Given this list of marker genes AGO3, CDH1, MYCN, MOV10, AGO2, MIR10B, MIR9-3, TNRC6C, AGO1 (NCBI Gene Id 26523), MIR9-2, MIR9-1, TNRC6B, AGO4, MYC, TNRC6A, here is a description of the gene set: Reactome Pathway: Regulation of CDH1 mRNA translation by microRNAs part of: Regulation of CDH1 Expression and Function <p>Regulation of CDH1 mRNA translation by microRNAs has not been extensively characterized. So far, miR-9 (miR-9-1, miR-9-2, and miR-9-3) microRNAs, whose expression is regulated by MYC/MYCN, and miR-10b were reported to directly regulate CDH1 mRNA translation by more than one study.</p><p>Other microRNAs implicated in the direct regulation of CDH1 microRNA expression by a single study include miR-23b, miR106a, miR-155, and miR-503.</p> species: Homo sapiens